The following is a description of a gene set: studied in species Mus musculus Pyroptosis Mouse Gene Set: REACTOME_PYROPTOSIS, and this is the list of marker genes: Il1a, Gsdmd, Bak1, Gsdme, Chmp2a, Bax, Hmgb1, Gzmb, Elane, Chmp6, Casp4, Chmp4c, Gm10053, Il1b, Chmp3, Il18, Casp1, Cycs, Casp3, Chmp7, Chmp4b, Chmp2b